Given this list of marker genes COCH, FOXD1, DDX24, PTPN2, CLEC4E, NCK2, PTHLH, JUNB, JARID2, CHRNA5, TASL, NONO, IRAK2, BTAF1, IRF9, HDC, TMEM171, CCNJ, TMEM248, CRTAM, CCDC6, GPR15, DDHD1, LTA, TIMELESS, HIVEP3, SLFN12, GMPPB, GSDMD, GSAP, UPP1, GBP7, CHIC2, HMGA1, ARHGEF37, ACAA1, P2RY13, RARS1, MBD2, GTDC1, TENT5A, TIMM23, TIFA, RCN2, CUTC (cutC copper transporter), ARB2A, ARID4A, CFB, TSC22D1, SEC24D, IL33, CSNK1D, MRPL27, B4GALT5, FPR2, UTP3, ADHFE1, PAFAH1B1, DAAM1 (NCBI Gene Id 23002), NMRK2, SOCS3, TANK, CEMIP2, DCBLD2, CSRP1, GNL1, HDAC1, TMEM68, PCYT1A, NOD1, TNFAIP2, NAB1, IL36G, TRAF1, URGCP, SLCO3A1, PMVK, PHC2, POLR2C, RNPEP, RAB9A, PCP4, ATF3, GPR182, WDR86, GRAMD2B, GLS, TRAF2, CCDC86, CGAS, FOXA1, ADAM17 (NCBI Gene Id 6868), TOP3A, MAFK, PLK2, PPP2R2A, ARMCX6, ENPP4, NECTIN4, GLRX, GPRC5D, GPR65, CASP8, TXN, RAB22A (NCBI Gene Id 57403), SEC23B, RGS16, SERPING1, STX12, IFT22, USP42, ANPEP (NCBI Gene Id 290), SNN, COX15, ZYX, EDN1, PPA1, LPIN2, HRH2 (histamine receptor H2), TEX14, CRLF3, GALNT14, MLKL, H3-5, FRMD4B, CREB5, NAMPT, NSD3, GP5, TENT4A, DNAJA2, BIRC2, PEX13, SPSB1, GPD2, IFI44, SLC12A9, TMED8, TEX35, POLR2G, MROH9, SCHIP1, NFIA (NCBI Gene Id 4774), OLR1, RHBDF2, DUSP16, SMOX, TAF4B, LY6E, ANKIB1, TMPO, HMGN3, PTGS2, MAP2K1 (NCBI Gene Id 5604), LARP1, HCAR2, DBR1, ICAM1, P2RY14, MOB3C, PIK3AP1, RASA4, KEAP1, ANKRD17, XKR8, FEZ2, PIGV, BLOC1S6, CCND1, AFG2B, WDR43, RGS2, BCL10, TRMT1L, ADAMTS19, PDCD10, SOCS7, BIRC3, SLC43A1 (NCBI Gene Id 8501, solute carrier family 43 member 1), TLK2, ARID5A, MZF1, PI4K2A, RGS1, SAT1, ASCL1, ZFP36, ANXA4, TMEM184B (transmembrane protein 184B), MORF4L1, PDE4B, TXNDC9, TMEM243, RAB20, COG6 (NCBI Gene Id 57511), YTHDF1, NIBAN1, UBR4, TLR3, TLR7, here is a description of the gene set: Human Gene Set: GSE2197_IMMUNOSUPPRESSIVE_DNA_VS_UNTREATED_IN_DC_UP studied in species Homo sapiens Bone marrow-derived dendritic cells were left untreated or stimulated with lipid-transfected double-stranded DNA or CpG oligonucleotides for four hours before harvesting. Genes up-regulated in comparison of dendritic cells (DC) treated with immunosuppressive DNA versus the untreated cells. from publication Stetson DB, Medzhitov R (PMID 16413926)